The following is a description of a gene set: Genes having at least one occurence of the motif AGTTCTC in their 3' untranslated region. The motif represents putative target (that is, seed match) of human mature miRNAs hsa-miR-146a and hsa-miR-146b (v7.1 miRBase). species: Homo sapiens Human Gene Set: AGTTCTC_MIR146A_MIR146B, and this is the list of marker genes: KCTD15, NPAS4, PTGFRN, ELAVL1, EIF4G2, CASK, PTPRA, TRAF6, STX3, HNRNPD, HIC2, ARHGAP6, BIVM, CFAP47, BCORL1, USP3, RARB, CCDC117, MMP16, ZFX, POLR3H, IRAK1, NUMB, RNF31, SNX22, RPS6KB2, DTNA, NOVA1, STRBP, CELF2, SP8, VASN, HMBOX1, ZNF512B, SEC23IP, STC1, CD79B, PCDH1, IVNS1ABP, LRRC15, KLF7, SYT1, PSMD3, PHF20L1, OBSCN-AS1, SRSF6, TUBA4B, SMAD4, JAZF1, KDM2B, HIPK1, PRX, DLGAP1, NRP2, ZNF532, TM6SF2, THRB, THUMPD3-AS1, RUNX1T1